The following is a description of a gene set: Genes predicted to be targets of miRBase v22 microRNA mmu_miR_219a_5p in miRDB v6.0 with MirTarget v4 prediction scores > 80 (high confidence targets). from publication Chen Y, Wang X (PMID 31504780) Mouse Gene Set: MIR_219A_5P species: Mus musculus, and this is the list of marker genes: Add2, Sox6, Gprc5b, Fam199x, Trhde, Prg4, Rars1, Ttc19, Slc31a1, Clasp1, Isl1, Bicral, Kbtbd8, Sh3d19, Krt222, Mrtfa, Gxylt1, Srek1, Cbx2, Laptm4a, Zeb2, Ddah1, Ascl2, Pcdh19, Erg (ETS transcription factor), Eya2, Ptgs2, Rps23rg1, Rassf3, Elovl7, Armc8, Nubpl (NCBI Gene Id 76826), Mef2d, Scai, Slc16a7, Dnal1, Dnajc6, D630045J12Rik (RIKEN cDNA D630045J12 gene), Zfp704, Elmod2, Pigr, Skida1, Mms19, Fzd4 (frizzled class receptor 4), Ccna2, Dsc1, Ddit4l, Pdgfra, Mier3, Ankrd44, Or10d5j, Tsc22d2, Lgalsl, Slk, Fam163a, Tpcn1, Pigg, Inpp5j, Klb, Tenm2, Dcaf10, Chd7, T, Nipa2, Tmem229a, Ube2z, Slc41a1 (NCBI Gene Id 98396), Ash1l (NCBI Gene Id 352974), Thrb, Akap6, Lrrc8a, Syt5, Kcnj2, Rorb, Rbm24, Epha7, Khdc1b, Sfmbt1, Sap130, Sdk1, Reck, Rtl4, Ubr1, Ror1, Fhip1b, Crlf3, Ccdc177, Purg, Dcbld2, Snrk, Cd2ap, Cxxc5, Ube3a, Prdm16, Tesc, Reps2, Cbr4, Camk1d, Kcnh8, Strbp, Rhbg, Mbnl1, Foxj3, Cgnl1, Mecom (NCBI Gene Id 58253), Sema4g, Sp4, Tceal7, Atg14, Rbms3, Pcdh17, Rab35, Zbtb18, Clock, Dazap1, Dpt, Ppargc1a, Tmem98, Wee1, Kcna4, Hoxd13